The following is a description of a gene set: species: Homo sapiens Jerky ocular pursuit movements Human Gene Set: HP_JERKY_OCULAR_PURSUIT_MOVEMENTS, and this is the list of marker genes: KCNC3, TTBK2, GBA2, PRNP, GDAP2, SPTBN2, PLD3, AARS1, SYNE1